Given this list of marker genes DAZL, ESRRB, PECAM1, STRA8, NR0B1, TBX3, ZFP42, PIWIL2, here is a description of the gene set: The application of human embryonic stem (ES) cells in medicine and biology has an inherent reliance on understanding the starting cell population. Human ES cells differ from mouse ES cells and the specific embryonic origin of both cell types is unclear. Previous work suggested that mouse ES cells could only be obtained from the embryo before implantation in the uterus. Here we show that cell lines can be derived from the epiblast, a tissue of the post-implantation embryo that generates the embryo proper. These cells, which we refer to as EpiSCs (post-implantation epiblast-derived stem cells), express transcription factors known to regulate pluripotency, maintain their genomic integrity, and robustly differentiate into the major somatic cell types as well as primordial germ cells. The EpiSC lines are distinct from mouse ES cells in their epigenetic state and the signals controlling their differentiation. Furthermore, EpiSC and human ES cells share patterns of gene expression and signalling responses that normally function in the epiblast. These results show that epiblast cells can be maintained as stable cell lines and interrogated to understand how pluripotent cells generate distinct fates during early development. species: Mus musculus Genes down-regulated in mES cells (mouse embryonic stem cells) after tratment with JAK inhibitor I. Human Gene Set: TESAR_JAK_TARGETS_MOUSE_ES_D3_DN from publication Tesar PJ, Chenoweth JG, Brook FA, Davies TJ, Evans EP, Mack DL, Gardner RL, McKay RD (PMID 17597760)